The following is a description of a gene set: species: Homo sapiens The appearance of chemokine (C-C motif) ligand 5 due to biosynthesis or secretion following a cellular stimulus, resulting in an increase in its intracellular or extracellular levels. Human Gene Set: GOBP_CHEMOKINE_C_C_MOTIF_LIGAND_5_PRODUCTION, and this is the list of marker genes: MUL1, TRPV4, IL10, SIRPA (NCBI Gene Id 96784), OAS3, DEFB124, DDX3X, ARG2, MAVS, MCOLN2, TICAM2, ADCYAP1